The following is a description of a gene set: species: Homo sapiens Human Gene Set: GOMF_WATER_CHANNEL_ACTIVITY Enables the energy-independent facilitated diffusion of water through a transmembrane aqueous pore or channel., and this is the list of marker genes: AQP10, AQP7B, MIP, AQP4, AQP3, AQP1 (aquaporin 1 (Colton blood group)), AQP6, PDPN, AQP12B, AQP12A, AQP11, AQP5, AQP2, AQP9, AQP7, AQP8